Given this list of marker genes HROB, SIRT1, POLD2, POLE2 (NCBI Gene Id 5427), POLE, ZBTB1, SPATA22, POLQ, TREX1, PCLAF, NYNRIN, POLK, WRN, PRIMPOL, POLI, SPRTN, REV1, RRM1, REV3L, PARP10, POLD3, POLDIP2, SYCP1, POLD4, USP1, VCP, POLH, RRM2B, DTL, POLA1, CDKN2D, WRNIP1, TEX12, POLN, USP43, PCNA, RCHY1, MAD2L2, RFC3, FAAP20, USP10, POLD1, here is a description of the gene set: studied in species Homo sapiens Human Gene Set: GOBP_DNA_SYNTHESIS_INVOLVED_IN_DNA_REPAIR Synthesis of DNA that proceeds from the broken 3' single-strand DNA end and uses the homologous intact duplex as the template.